Given this list of marker genes DPH3, NME1, MCM4, ENY2, PLEKHG2, RACGAP1, SUPT7L, DTYMK, SGO2, ANLN, NCAPG, UBE2T, MTERF3 (mitochondrial transcription termination factor 3), RRM2, IMMT, KNTC1, SMARCA5, NDC80, RBMX, TRUB2, HMGB3P1, CCT7, ATAD2, CENPA, SRP19, GEMIN6, AURKA, MAP4K4, TAF1A, CCT5, CMSS1, PRC1, CDKN3, NANS, EEPD1, CACYBP, TIMELESS, GMPS, SURF4, PRPF38B, CDCA5, CENPF, SMC2, TK1, CCNB2, HSPD1, GJC1, PRIM2, C8orf33, RBM33, GINS2, GLRX2, KDELR2, SNRPG, CREM, HTRA2, NUDT4, DDX18, DHFR, UHRF1, GPN3, PCNA, MRPS5, IWS1, FAM216A, OGG1, ZNF367, PCDH17, MRPS16, CCNB1, IPO7, CDC45, NEIL3, CDC6, FAM98A, DSCC1, H2AZ2, CHORDC1, VMA21, ECT2, PAICS, PTTG2, GMNN, NEK2, ARF4, TYMS, PHF14, DLGAP5 (NCBI Gene Id 9787), TOP2A, KIF11, CDON, NCAPH, NUF2, RANBP1, FERMT2, RPA3, XPO1, UBFD1, CEP55, MRPL32, RHBDL2, TLCD5, CHEK1, NSD2, CKS1B, KNSTRN, NASP, CLASP1, SHCBP1, RSRC1, SPC25, ZNF587, ASPM (assembly factor for spindle microtubules), MORF4, C9orf40, SSR3, KIF18B, CKS2, NCAPG2 (NCBI Gene Id 54892), KPNA2, TCOF1, DONSON, MCM6, PWP1, MSH6, PTTG1, MSANTD3, SRSF10, OLA1, PARPBP, UGGT1, MRPS17 (NCBI Gene Id 64958), SKA2, HSPA4, CDCA8, CNN3, HSPA5, CENPN, PCLAF, EXO1, ZWINT, KIF2C, CCT4, MRPS10, CDK1, PLOD2, KIRREL1, NUDCD1, NCBP1, CHTOP, DCBLD2, SPAG5, PSMC3IP, DNAJA1, TARS1 (threonyl-tRNA synthetase 1), CTNNAL1, BIRC5, RFC4, RFC5, BUB1, RAD54L, MELK, here is a description of the gene set: Genes from the 254-gene classifier which were up-regulated in melanoma patients with a reported distant metastasis within 4 years. Human Gene Set: WINNEPENNINCKX_MELANOMA_METASTASIS_UP BACKGROUND: Gene expression profiling data for human primary cutaneous melanomas are scarce because of the lack of retrospective collections of frozen tumors. To identify differentially expressed genes that may be involved in melanoma progression and prognosis, we investigated the relationship between gene expression profiles and clinical outcome in a cohort of patients with primary melanoma. METHODS: Labeled complementary RNA (cRNA) from each tissue sample was hybridized to a pangenomic 44K 60-mer oligonucleotide microarray. Class comparison and class prediction analyses were performed to identify genes whose expression in primary melanomas was associated with 4-year distant metastasis-free survival among 58 patients with at least 4 years of follow-up, distant metastasis, or death. Results were validated immunohistochemically at the protein level in 176 independent primary melanomas from patients with a median clinical follow-up of 8.5 years. Survival was analyzed with a Cox multivariable model and stratified log-rank test. All statistical tests were two-sided. RESULTS: We identified genes that were associated with distant metastasis-free survival of patients with primary melanoma. These genes include genes involved in activating DNA replication origins, such as minichromosome maintenance genes and geminin. Twenty-three of these genes were studied at the protein level; expression of five (MCM4, P =.002; MCM3, P =.030; MCM6, P =.004; KPNA2, P =.021; and geminin, P =.004) was statistically significantly associated with overall survival in the validation set. In a multivariable Cox model adjusted for tumor thickness, ulceration, age, and sex, expression of MCM4 (hazard ratio of death = 4.04, 95% confidence interval = 1.39 to 11.76; P =.010) and MCM6 (HR of death = 7.42, 95% CI = 1.99 to 27.64; P =.003) proteins was still statistically significantly associated with overall survival. CONCLUSION: We identified genes whose expression was associated with metastatic dissemination of cutaneous melanomas. These genes may shed light on the molecular mechanisms underlying poor prognosis in melanoma patients. from publication Winnepenninckx V, Lazar V, Michiels S, Dessen P, Stas M, Alonso SR, Avril MF, Ortiz Romero PL, Robert T, Balacescu O, Eggermont AM, Lenoir G, Sarasin A, Tursz T, van den Oord JJ, Spatz A, Melanoma Group of the European Organization for Research and Treatment of Cancer (PMID 16595783) species: Homo sapiens